Given this list of marker genes Socs4, Fbxw7, Zfyve28, Cblc, Neurl1a, Tsg101, Gprc5a, Chmp6, App, Vps25, Errfi1, Zgpat, Psen1, Psen2, Socs5, Aplp2, Adam17, here is a description of the gene set: studied in species Mus musculus Any process that modulates the frequency, rate or extent of EGF-activated receptor activity. Mouse Gene Set: GOBP_REGULATION_OF_EPIDERMAL_GROWTH_FACTOR_ACTIVATED_RECEPTOR_ACTIVITY